Given this list of marker genes Nbas, Secisbp2, Syncrip, Pabpc1 (poly(A) binding protein, cytoplasmic 1), Dhx34, Upf3a, A1cf, Hnrnpab, Apobec1, here is a description of the gene set: Mouse Gene Set: GOBP_NEGATIVE_REGULATION_OF_NUCLEAR_TRANSCRIBED_MRNA_CATABOLIC_PROCESS_NONSENSE_MEDIATED_DECAY studied in species Mus musculus Any process that stops, prevents or reduces the frequency, rate or extent of nuclear-transcribed mRNA catabolic process, nonsense-mediated decay.